Given this list of marker genes KCNMB4, KCNJ3, KCNJ8, KCNC2, KCNA4, SCN10A, KCNC1, KCNA2, KCNJ11, SCN1A, KCNQ5, here is a description of the gene set: Voltage-gated ion channel activity, occurring in the presynaptic membrane, involved in regulation of presynaptic membrane potential. This is a key step in synaptic transmission, following the arrival of an action potential at the synapse. species: Homo sapiens Human Gene Set: GOMF_VOLTAGE_GATED_MONOATOMIC_ION_CHANNEL_ACTIVITY_INVOLVED_IN_REGULATION_OF_PRESYNAPTIC_MEMBRANE_POTENTIAL